The following is a description of a gene set: studied in species Mus musculus Mouse Gene Set: MIR_466F_5P from publication Chen Y, Wang X (PMID 31504780) Genes predicted to be targets of miRBase v22 microRNA mmu_miR_466f_5p in miRDB v6.0 with MirTarget v4 prediction scores > 80 (high confidence targets)., and this is the list of marker genes: Fkbp4, Awat1, P4hb (prolyl 4-hydroxylase, beta polypeptide), Wdr33, Plppr1, Cend1, Rsbn1, Fzd4, Ifit1bl2, Emc3, Gng10, Rsu1, Bend3